The following is a description of a gene set: species: Mus musculus from publication Chen Y, Wang X (PMID 31504780) Mouse Gene Set: MIR_144_3P Genes predicted to be targets of miRBase v22 microRNA mmu_miR_144_3p in miRDB v6.0 with MirTarget v4 prediction scores > 80 (high confidence targets)., and this is the list of marker genes: Mef2a, Ube2d2a, Bmpr1b, Tfap4, Hif1a, Brd10, Slc23a2, Dennd2a, Acer3, Tet2, Slc12a2, Zeb1, Ube2d1 (ubiquitin-conjugating enzyme E2D 1), Slc5a7, Atp1b1, Tmtc3, Mrs2, Scn8a, Arhgap42, Mycn, Pfkfb2, Limch1 (NCBI Gene Id 77569), Cyp2c50 (NCBI Gene Id 226104), Cdh11, Erg, Ufm1, Sel1l, Map7d1, Pds5b (PDS5 cohesin associated factor B), Rin2, Pura, Fzd8, Idh2, Son, Slc16a12, Prpf39, Fam222b, Als2 (NCBI Gene Id 77293), Prss41, Med14, Eif5, Afap1, Sorcs3, Nrp2, Socs7, Map3k4, Slc25a36, Slco3a1, Hccs, Lratd1, Sec24a, Zfyve27, Nptx1, Ptprj, Acbd3, Pcdh18, Hycc2, Col10a1, Zc3h11a (zinc finger CCCH type containing 11A), Dip2b, Pafah1b1, Met, Htra3, Prr11, Meis2, Scn1a, Eif5a2, Selenoi, Insc, Eml1, Smarca4, Arid2, Cxcl12, Pik3c2a, Begain, Zfx, Med4, Pank1, Fndc3a, Trim2, Ppp2r2a, Med12l, Dipk2a (divergent protein kinase domain 2A), Uchl3, Cpeb2, Robo2, Mmrn1, Usp46, Cilk1, Nr1d2, Qki, Rnaseh1, Gclc, Zbtb34, Plekhg1, Cdk8, Teddm1b, Cds1, Mtmr2, Kat6a, Itsn2, Erbin, Uba2, Fat4, Gdf10, Magi1, Rbm27, Cpsf6, Oprk1 (NCBI Gene Id 18388), Iigp1c (interferon inducible GTPase 1C), Serpini1, Kctd10, Kifc5b, Tnfsf11, Adamts3, Pbx3, Sinhcaf, Tm9sf3, Sacm1l, Dok4, Sap30l, Tmem86b, Ubr3, Sh3tc2, Gbe1, Sucla2, Zfp36l2, Trappc8, Klf12, Nfe2l2, Slc4a10, Ptpn12, Zbtb37, Gspt1, Pfkl, Arid1a, Usp42, Rarb, Zfp827, Atp6v1a, Sh2b3, Ppp1r16b, Ino80d, Kcnmb2, Vps4b, Cttnbp2, Afdn, Impact, Magt1 (NCBI Gene Id 69751), Zdhhc21, Tek, Dtwd1, Gata3, Lsm14a, Mrtfb, Wsb1, Skor1, Ap1g1, Bach2 (NCBI Gene Id 319905), Zfp148, 1110004F10Rik, Fos, Kif2a, Aplp2, Tada2b, Naa15, Plxnc1, Bicd2, Sall1, Dlg5, Ptchd4, Ptpn9, Adamts15, Atxn1, Shisa6, Rnf111, Copg1, Rfx3, Iigp1, Mapk6, Dr1, Etnk1, Adamtsl3, Zbtb21, Abca1, Tshz3, Abtb2, Aspn, Asap2, Morn4, Wif1, Sec24b, Ube2a, Clint1 (clathrin interactor 1), Shcbp1, Slc12a8, Lrrc39, Smarca1, Trim44, Zcchc2, Cct6a, Ipo8, Ppp3r1, Hnrnpf, Ugp2, Uchl4 (ubiquitin carboxyl-terminal esterase L4), Nin, Nlk, Tbl1xr1, Suclg2, Emp2, Ssb, Stard8, Pde7b, Zc3h12c, Or2ag2b, Prickle1, Senp7, Nacc2, Togaram1 (TOG array regulator of axonemal microtubules 1), Tmem184c (transmembrane protein 184C), Thap1, Gask1a, Ssx2ip, Zfp207, Herpud1, Garnl3, Mbnl1, Drp2, Akr1c14, 6030498E09Rik, Hdac2, Ro60, Thsd7a, Kcnj6, Bmpr1a, Ctla2b, Add3, Ss18, Cdyl, Smoc1, Mycl, Myo1e, Slc7a11, Klf8, Zbtb18, Heatr5b, Cep68, Hnrnpu, Ccng2, Flrt3, Rap2c, Fbxw11 (F-box and WD-40 domain protein 11), Atp2b2, Crebrf, Rbm41, Elavl2, Eif4g2, Cobll1, Mob4, Adamts17, Atpaf1, Atp5mc2, Tmem196, Atp2b1, Kcnh8, Pla2g4a, Irs1, Cav3, Pnrc1, Sp4, Arhgap26, Gja1, Hspbap1, Epn2, Cadm2, Otud4, Pdcl, Ubxn7, Ddx59, Smad4, Ms4a4c, Rac1, Phlda1, Fam76b (family with sequence similarity 76, member B), Ehmt1 (NCBI Gene Id 77683), Pde3b, Dsc3, Gxylt1, Mcf2l, Syncrip, Kcnd2, Smpd3, Ube2g1, Marf1, 1700067P10Rik, Golt1b, Nr2f2, Nup37, Tle1, Fbn2, Fzd6, Pcsk5, Msx1, Ttn, Ptp4a1, Pptc7, Rnft1, Zfp619, Rbm48, Phf3, Col8a1, Grm5, Ppfia1, Ets1, Nid2, Tjp1 (tight junction protein 1), Acsl4, Frs2, Stc1, Kdm3a, Brpf1, Scfd1, Ibsp, Pex11b, Dcbld2, Edem1, Ccdc85a, Sgpp1, Plekha7, Rexo1, Vkorc1l1, Slc1a1 (solute carrier family 1 (neuronal/epithelial high affinity glutamate transporter, system Xag), member 1), Tnrc18, Cacna2d1, Glcci1, Hdac9, Igip, Tfrc, Iqsec1, E2f8, Uevld, Wee1, Bbx, Pthlh, Kitl, Aldh1a3, Ube2d3, Cmc1, Emp1, Sco1, Megf9, Ccdc88a